Given this list of marker genes TSPAN11, GGT7, CORO1A, EPN3, FOXS1, PAK5, PROKR1, EVPL, TSSK3, TNFRSF13C, ADAM33, MOGAT1, LYL1, CNMD, here is a description of the gene set: from publication Meissner A, Mikkelsen TS, Gu H, Wernig M, Hanna J, Sivachenko A, Zhang X, Bernstein BE, Nusbaum C, Jaffe DB, Gnirke A, Jaenisch R, Lander ES (PMID 18600261) DNA methylation is essential for normal development and has been implicated in many pathologies including cancer. Our knowledge about the genome-wide distribution of DNA methylation, how it changes during cellular differentiation and how it relates to histone methylation and other chromatin modifications in mammals remains limited. Here we report the generation and analysis of genome-scale DNA methylation profiles at nucleotide resolution in mammalian cells. Using high-throughput reduced representation bisulphite sequencing and single-molecule-based sequencing, we generated DNA methylation maps covering most CpG islands, and a representative sampling of conserved non-coding elements, transposons and other genomic features, for mouse embryonic stem cells, embryonic-stem-cell-derived and primary neural cells, and eight other primary tissues. Several key findings emerge from the data. First, DNA methylation patterns are better correlated with histone methylation patterns than with the underlying genome sequence context. Second, methylation of CpGs are dynamic epigenetic marks that undergo extensive changes during cellular differentiation, particularly in regulatory regions outside of core promoters. Third, analysis of embryonic-stem-cell-derived and primary cells reveals that 'weak' CpG islands associated with a specific set of developmentally regulated genes undergo aberrant hypermethylation during extended proliferation in vitro, in a pattern reminiscent of that reported in some primary tumours. More generally, the results establish reduced representation bisulphite sequencing as a powerful technology for epigenetic profiling of cell populations relevant to developmental biology, cancer and regenerative medicine. Human Gene Set: MEISSNER_ES_ICP_WITH_H3K4ME3_AND_H3K27ME3 studied in species Mus musculus Genes with intermediate-CpG-density promoters (ICP) bearing histone trimethylation marks at K4 (H3K4me3) and K27 (H3K27me3)ES cells (embryonic stem).